The following is a description of a gene set: studied in species Homo sapiens Circadian clock Human Gene Set: REACTOME_CIRCADIAN_CLOCK, and this is the list of marker genes: RORB, PSMA2, F7 (coagulation factor VII), PSMB1, BHLHE41, CSNK1D, PER2, PSMD6, PSMB3, BHLHE40, UBB, AVP, CRTC1, CSNK2A2, HDAC3, PSMC4, PSMA6, PPARGC1A, PPP1CC, CPT1A, FBXL3, KLF15, PSMD12, CHD9 (chromodomain helicase DNA binding protein 9), PSMD1, NCOA6, SERPINE1, PSMB6, PSMC2, PSMD7, PER1, CREB1, PSMB2, RORA, PSMA1 (NCBI Gene Id 5682), PSMA5, CARM1, KMT2A, CRY1, CREM, RPS27A, PSMD14, UBA52, ELOVL3, RXRA, PSMB7, CRTC2, PSMD3, CREBBP, TBL1XR1, RORC, NAMPT (NCBI Gene Id 10135), NCOR1, PSMA4, SREBF1, PSMA7, SIK1, DBP, PSMD13, MED1 (mediator complex subunit 1), UBC, PSMD11, TFEB, PSMB5, TGS1, HELZ2, SEM1, RBM4, CRTC3, EP300, FBXW11, SKP1, PSMD2, MEF2C, PPARA, PSMC6, CSNK1E, PSMA3, NRIP1, CIPC, CUL1 (NCBI Gene Id 8454), RBX1 (ring-box 1), PSMD8, MEF2D, PER3, PPP1CA, BMAL1 (basic helix-loop-helix ARNT like 1), SMARCD3, NCOA1 (NCBI Gene Id 8648), NPAS2, ADRM1, NR1D1, CRY2, PSMC5, TBL1X, RAI1, PSMC3, BMAL2, PPP1CB (NCBI Gene Id 5500), PSMC1, UBE2D1 (ubiquitin conjugating enzyme E2 D1), ATF2, CDK5, CLOCK, NCOA2, CSNK2A1, BTRC, CSNK2B, USP46, PSMB4, SIRT1 (sirtuin 1), NOCT